Given this list of marker genes TUBA4A, PCDH7, ACTN2, NEK4, STK24, GLDC, STMN2, TRIP12, LANCL2, CCRL2, C1QTNF1, THUMPD3, IKBKB, CXCL3, CAV1, STEEP1, PHLDA1, GLUD1, SYP, AGO2, MYL1, ZBTB14, SSTR4, NAA38, IL1A, SARAF, AK4, CCDC88A, CEBPA, TRAF5, INTS14, FAM107B, CNOT6L, SYT1, RPL39, DNASE1L1, ITLN1, RFXANK (NCBI Gene Id 8625), NSG1, NUMB, DUSP19, TSKU, BCAR1, MYT1L, MDK (midkine), WRN, TRAF1, C9orf72, LDHB, LLGL1, EIF4EBP1, CDC73, CCL22, MMP13, CTBP2, NAB2, CCKAR, ADCY6, CLEC4F, S100A6, P2RX6, CTSE, DLGAP4, ZDHHC6, PNP, IL6, SERPINF1 (serpin family F member 1), TANGO2 (transport and golgi organization 2 homolog), TNNI3, CDH1, GLUL, GJA4, KLF5, LMO7, ARL5A, GSDME, NCK2, TOX4, LIFR, IL15RA, ZP1, D2HGDH, GALE, SNHG6, SNAI1, SMAP2, BMAL1, PLS3, CSF1, MAPRE1, FZD2, PLAT, LPL, DNAJB2, SLC20A1, LY6E, TPGS2, MRPS18A, CCT6A, CDH16, TOB1, RPL39L, MAPRE3, SLC23A2 (NCBI Gene Id 9962), PTRH1, POLR2M (RNA polymerase II subunit M), C1orf174, PIPOX, NUDCD2, MAP4K3, CCN2, CXCL13, RBP2, GDNF, VCAM1, RNF11, POSTN, EGR2, CAPZA3, SEMA4F, NF1, PTPRE, RCAN1, ARL4D, PPP3CB, KPNA3, WDSUB1, C2CD2, PSEN2, CRYBG1, RGS5 (regulator of G protein signaling 5), CASC3, CLGN, GFI1, CAT, KCMF1 (potassium channel modulatory factor 1), PRKACB, HOXD9, ANG, TOP1 (NCBI Gene Id 7150), RNF103, RRP9, PITPNA, DKK2, NECTIN2, AMOTL2, ACSS1, ANKRD33B, PTTG1, MFHAS1, RSAD2, NDRG4, UPP1, PML, IL12RB2, PCID2, FOXL1, CMPK2, SCHIP1, EMP2, FRMD6, RBFOX2, ARL1, HAGH, IRS2 (NCBI Gene Id 90066), KRT1 (keratin 1), RCN1, AGPAT1, TWIST2, SSPOP, CHRNA7, CHRM1, UTY, RBBP9, CA12, SP1, LAMB2, DNAJB6, KDR, IPO5, SPECC1, ITGA5, SLC22A18, HBG2, MX2, NEDD1, FZD8, RGS8, P4HA2 (prolyl 4-hydroxylase subunit alpha 2), DAZ2, FN1, AHI1, NID2, PRKCD, CACNB3, FBXL3, COL1A1, CISH, CCND1, IRF5, here is a description of the gene set: Human Gene Set: GSE43955_1H_VS_60H_ACT_CD4_TCELL_WITH_TGFB_IL6_DN Despite their enormous importance, the molecular circuits that control the differentiation of Th17 cells remain largely unknown. Recent studies have reconstructed regulatory networks in mammalian cells, but have focused on short-term responses and relied on perturbation approaches that cannot be applied to primary T cells. Here, we develop a systematic strategy – combining transcriptional profiling at high temporal resolution, novel computational algorithms, and innovative nanowire-based tools for performing gene perturbations in primary T cells – to derive and experimentally validate a temporal model of the dynamic regulatory network that controls Th17 differentiation. The network is arranged into two self-reinforcing and mutually antagonistic modules that either suppress or promote Th17 differentiation. The two modules contain 12 novel regulators with no previous implication in Th17 differentiation, which may be essential to maintain the appropriate balance of Th17 and other CD4+ T cell subsets. Overall, our study identifies and validates 39 regulatory factors that are embedded within a comprehensive temporal network and identifies novel drug targets and organizational principles for the differentiation of Th17 cells. Genes down-regulated in CD4 T helper cells Th17 treated with TGFB1 and IL6: 1h versus 60h. from publication Yosef N, Shalek AK, Gaublomme JT, Jin H, Lee Y, Awasthi A, Wu C, Karwacz K, Xiao S, Jorgolli M, Gennert D, Satija R, Shakya A, Lu DY, Trombetta JJ, Pillai MR, Ratcliffe PJ, Coleman ML, Bix M, Tantin D, Park H, Kuchroo VK, Regev A (PMID 23467089) studied in species Homo sapiens